The following is a description of a gene set: Mouse Gene Set: GOBP_RECEPTOR_MEDIATED_ENDOCYTOSIS_INVOLVED_IN_CHOLESTEROL_TRANSPORT A receptor-mediated endocytosis process involved in intracellular cholesterol transport. studied in species Mus musculus, and this is the list of marker genes: Anxa2, Abca2, Ldlrap1, Lrp6, Pcsk9, Ldlr